Given this list of marker genes VAMP4, MLLT3, MN1, RAB27A, TGFBR1, TPM4 (NCBI Gene Id 7171), PGRMC1, RGS12, TCF4, LRRC58, SGK1, RAB32, GAS2L1, CRIP2 (cysteine rich protein 2), NCKAP1, MTUS1, CPNE3 (copine 3), PCBD2, RECQL, here is a description of the gene set: Dominant RUNX1 inhibition has been proposed as a common pathway for CBF leukemia. CBF beta-SMMHC, a fusion protein in human acute myeloid leukemia (AML), dominantly inhibits RUNX1 largely through its RUNX1 high-affinity binding domain (HABD). However, the type I CBF beta-SMMHC fusion in AML patients lacks HABD. Here, we report that the type I CBF beta-SMMHC protein binds RUNX1 inefficiently. Knockin mice expressing CBF beta-SMMHC with a HABD deletion developed leukemia quickly, even though hematopoietic defects associated with Runx1-inhibition were partially rescued. A larger pool of leukemia-initiating cells, increased MN1 expression, and retention of RUNX1 phosphorylation are potential mechanisms for accelerated leukemia development in these mice. Our data suggest that RUNX1 dominant inhibition may not be a critical step for leukemogenesis by CBF beta-SMMHC. Human Gene Set: KAMIKUBO_MYELOID_MN1_NETWORK species: Mus musculus Network of differentially expressed myeloid genes centered around MN1. from publication Kamikubo Y, Zhao L, Wunderlich M, Corpora T, Hyde RK, Paul TA, Kundu M, Garrett L, Compton S, Huang G, Wolff L, Ito Y, Bushweller J, Mulloy JC, Liu PP (PMID 20478528)